The following is a description of a gene set: species: Homo sapiens Any process that decreases the rate, frequency or extent of fibroblast cell migration. Fibroblast cell migration is accomplished by extension and retraction of a pseudopodium. Human Gene Set: GOBP_NEGATIVE_REGULATION_OF_FIBROBLAST_MIGRATION, and this is the list of marker genes: BRAF, HYAL2, FGF2, MIR19A, MACIR, RAC1, ARHGAP4, HAS1, NHERF1, ZEB2, ITGB1BP1, MIR19B1, CYGB